Given this list of marker genes SDHD, METTL27, CDKN2B, ANKH, BTNL2, SLC12A1, NOTCH3, BCL6, SDHC, GTF2I, WT1, APC2, DLST, CDKN2C, CLIP2, AP2S1, ALPL, SDHA, CASR, HLA-DRB1, BRCA2, RFC2, FH, PDGFRB, PIK3C2A, MLXIPL, DIS3L2, CYP24A1, BAZ1B, GPC3, SDHB, SLC25A11 (solute carrier family 25 member 11), SDHAF2, STX1A, TNFRSF11A, VHL, SLC34A1, ELN, POU6F2, NSD1, CDKN1B, GTF2IRD2, DNMT3A, MEN1, BCL2, GALNT3, GTF2IRD1, BUD23, MDH2, DNAJC30, CDKN1A (NCBI Gene Id 1026), GCM2, TRIO, TMEM127, TBL2, CDC73, TMEM270, CCND1, MAX, PTH1R, LIMK1, CDKN1C, NCF1, KIF1B, H19, LDHA, EPAS1, SLC5A1, GNA11, KL, TRIP13, REST, CRELD1 (cysteine rich with EGF like domains 1), FKBP6, NF1, ZFX, VPS37D, PIGT, EIF4H, TRIM28, RET, here is a description of the gene set: Human Gene Set: HP_HYPERCALCEMIA Hypercalcemia species: Homo sapiens An abnormally increased calcium concentration in the blood.